Given this list of marker genes IL4, SELE, SERPINE1, PLCG2, HFE, DTNBP1, BICD1, NTF3, AP2M1, CCL19, WNT3A, MAGI2, C3, PICK1, DRD2, VTN, H1-1, TBC1D5, SYK, AP2A1, HIP1, PPT1, FMR1, SFRP4, HAMP, DAB2, CD63, INSR, PCSK9, DGKD, ANXA2, APOA5, TF, ARRB2, EGF, ANXA2P2, APLNR, APELA, ARRB1, ANGPT1, APLN, WASL, APP, SGIP1 (NCBI Gene Id 84251), B2M, CBL, VEGFA, GREM1, AHI1, LDLRAP1, CLU, RAB21, GH1, CCR7, ATAD1, CCL21, here is a description of the gene set: species: Homo sapiens Human Gene Set: GOBP_POSITIVE_REGULATION_OF_RECEPTOR_MEDIATED_ENDOCYTOSIS Any process that activates or increases the frequency, rate or extent of receptor mediated endocytosis, the uptake of external materials by cells, utilizing receptors to ensure specificity of transport.